Given this list of marker genes CSF1R, TP53, HDAC1, IRAK3, MAVS, ITGB2, AZI2, IL6R, ICAM2, IRF8, MAP3K7, ITGAL, EIF2S1, ERAP1, KAT2B, IRF3 (interferon regulatory factor 3), CREBBP, CD244, PTPN6, IFI16, TRADD (TNFRSF1A associated via death domain), JUN, UBA7, IL27RA, BCL2, C3AR1, DNAJA3, ITGA4, STAT6, SMARCA4, HDAC2, APOBEC3G, IKBKB, here is a description of the gene set: Human Gene Set: NAKAYA_PBMC_FLUMIST_AGE_18_50YO_7DY_IFN_SUBSET_UP Here we have used a systems biology approach to study innate and adaptive responses to vaccination against influenza in humans during three consecutive influenza seasons. We studied healthy adults vaccinated with trivalent inactivated influenza vaccine (TIV) or live attenuated influenza vaccine (LAIV). TIV induced higher antibody titers and more plasmablasts than LAIV did. In subjects vaccinated with TIV, early molecular signatures correlated with and could be used to accurately predict later antibody titers in two independent trials. Notably, expression of the kinase CaMKIV at day 3 was inversely correlated with later antibody titers. Vaccination of CaMKIV-deficient mice with TIV induced enhanced antigen-specific antibody titers, which demonstrated an unappreciated role for CaMKIV in the regulation of antibody responses. Thus, systems approaches can be used to predict immunogenicity and provide new mechanistic insights about vaccines. from publication Nakaya HI, Wrammert J, Lee EK, Racioppi L, Marie-Kunze S, Haining WN, Means AR, Kasturi SP, Khan N, Li GM, McCausland M, Kanchan V, Kokko KE, Li S, Elbein R, Mehta AK, Aderem A, Subbarao K, Ahmed R, Pulendran B (PMID 21743478) studied in species Homo sapiens Genes up-regulated in peripheral blood mononuclear cell 7d vs 0d in adults (18-50) after exposure to FluMist, time point 7D. Comment: Molecular signature induced by LAIV vaccination. (a) Interferon (IFN)-related genes differentially expressed after LAIV vaccination